The following is a description of a gene set: Mouse Gene Set: GOMF_VERY_LOW_DENSITY_LIPOPROTEIN_PARTICLE_BINDING species: Mus musculus Binding to a very-low-density lipoprotein particle, a triglyceride-rich lipoprotein particle that is typically composed of APOB100, APOE and APOCs and has a density of about 1.006 g/ml and a diameter of between 20-80 nm., and this is the list of marker genes: Pltp, Pcsk9, Ihh (Indian hedgehog), Vldlr, Trem2